Given this list of marker genes TRMT10C, PRORP, FASTKD3 (NCBI Gene Id 79072), RPUSD4, FASTK, CDK5RAP1, TBRG4, PUS1, PNPT1, FASTKD5, SUPV3L1, GTPBP3, HSD17B10, ELAC2, TRMT61B, FASTKD1, MTPAP, FASTKD2, METTL8, ANGEL2, MTO1, TRMT5, TRIT1, TRNT1, here is a description of the gene set: species: Homo sapiens The conversion of a primary RNA molecule transcribed from a mitochondrial genome into one or more mature RNA molecules; occurs in the mitochondrion. Human Gene Set: GOBP_MITOCHONDRIAL_RNA_PROCESSING